The following is a description of a gene set: A form of subcortical heterotopia with mislocalized gray matter within the white matter.It is defined as longitudinal bands of gray matter located deep to the cerebral cortex and separated from it by a thin layer of normal appearing white matter. It is part of the lissencephaly spectrum. Subcortical band heterotopia species: Homo sapiens Human Gene Set: HP_SUBCORTICAL_BAND_HETEROTOPIA, and this is the list of marker genes: EML1, TUBGCP2, LAMB1, CEP85L (centrosomal protein 85 like), TUBG1, DCHS1, TUBB, KIF2A, FAT4, PAFAH1B1